Given this list of marker genes MDN1, BOP1, RRS1, NIP7, RRP15 (NCBI Gene Id 57241), RPF1, NSA2, WDR74, MAK16, PPAN, WDR12, FTSJ3, ZNF622, NOC2L, EBNA1BP2, MRTO4, PES1, here is a description of the gene set: Human Gene Set: GOCC_PRERIBOSOME_LARGE_SUBUNIT_PRECURSOR studied in species Homo sapiens A preribosomal complex consisting of 27SA, 27SB, and/or 7S pre-rRNA, 5S rRNA, ribosomal proteins including late-associating large subunit proteins, and associated proteins; a precursor of the eukaryotic cytoplasmic large ribosomal subunit.